Given this list of marker genes ABCC8, GLYCTK, UCP2, HMGCS2, AKT2, HADH, KCNJ11, LMNA, ACADVL, HNF1A, DOLK, here is a description of the gene set: Any deviation from the normal concentration of a free fatty acid in the blood circulation. Abnormal circulating free fatty acid concentration Human Gene Set: HP_ABNORMAL_CIRCULATING_FREE_FATTY_ACID_CONCENTRATION studied in species Homo sapiens